The following is a description of a gene set: Human Gene Set: GOMF_INORGANIC_DIPHOSPHATE_PHOSPHATASE_ACTIVITY Catalysis of the reaction: diphosphate + H2O = H+ + 2 phosphate. studied in species Homo sapiens, and this is the list of marker genes: PRUNE1, PPA2, ALPL, LHPP, PPA1